The following is a description of a gene set: Human Gene Set: GOMF_LAMIN_BINDING Binding to lamin; any of a group of intermediate-filament proteins that form the fibrous matrix on the inner surface of the nuclear envelope. species: Homo sapiens, and this is the list of marker genes: AKAP8L, TMEM201, SYNE1, SUN1, PRNP, TOR1AIP1, BNIP3L, PLCB1, LBR, MLIP, PPP1CC, NARF, TMPO, IFI27, PKP1, SUN2